Given this list of marker genes P4hb, Ero1a, Hoga1, P4ha2, Egln2, Prdx4, Ero1b, P4ha1, here is a description of the gene set: The chemical reactions and pathways involving 4-hydroxyproline, C5H9NO3, a derivative of the amino acid proline. The presence of hydroxyproline is essential to produce stable triple helical tropocollagen, hence the problems caused by ascorbate deficiency in scurvy. This unusual amino acid is also present in considerable amounts in the major glycoprotein of primary plant cell walls. Mouse Gene Set: GOBP_4_HYDROXYPROLINE_METABOLIC_PROCESS studied in species Mus musculus